The following is a description of a gene set: Human Gene Set: E2F1DP1RB_01 Genes having at least one occurrence of the motif TTTSGCGC in the regions spanning 4 kb centered on their transcription starting sites. This matches the E2F1, TFDP1, RB1 transcription factor binding site V$E2F1DP1RB_01 (v7.4 TRANSFAC). studied in species Homo sapiens, and this is the list of marker genes: CAND1, POLA2, RAB11B, MCMBP, E2F8, ATAD2, ATF5, POU4F1, SYNGR4, RTBDN, SRSF1, PRPS1, PAN2, MCM8, RFC1, PODN, POLR2A, TRMT13, UBR7, ZBTB4, HOXC10, CBX5, ZSWIM9, YTHDC1, ARHGAP11A, CORT, DCK, NIPBL, DNMT1, ILF3-DT, MCM6, PPM1D, CDT1, EZH2, GMNN, NFATC2IP, EMSY, GRIA4, ALDH6A1, PEG3, SLC9A5, SPTB, ZIM2, TMEM143, MTF2, MAPT, STMN1, CCNT1, RBPJ, TYRO3, ONECUT1, PPIG, TRMT6, RAD51, IMPDH2, ANKHD1-EIF4EBP3, RAVER1, ASXL2, JADE1, RMI2, JADE2, SRSF7, NRP2, SMC3, STAG2, SIK2, GABRB3 (NCBI Gene Id 2562), PRRC2C, INTS7 (integrator complex subunit 7), EPHB1, ATRX, POLR1G, DNAJC11, CTDSP1, IL4I1, ID3 (NCBI Gene Id 3399), ARHGAP6, HNRNPA1, KMT5A, POLE2, SRSF2, HNRNPUL1, DPYSL2, FHOD1, BRME1, ZNF565, PPP1R8, CDC25A, NECTIN1, RET, ARID4A, DMD, PCNA, KCNA6, MXD3, GSPT1, TMPO (NCBI Gene Id 7112), TLE3, MCM7, OTUD7B, MSH2, PNMA3, LHX5, ADAMTS2, LUC7L3, UGGT1, E2F1, WDR62 (WD repeat domain 62), MCM3, NASP, ZNF367, NUFIP2, GEN1, ING3 (NCBI Gene Id 54556), POLD1, ZNF362, ACBD6, STK35, IPO7, SOAT1, SLCO3A1, HNRNPD, PCSK1, OLFML3, KBTBD6, ILF3, CTCF, FIZ1, HCN3, ZNF524, SMAD6, EIF1AX, ZNF644, EED, LIG1, AP4M1, CASP8AP2, RPS6KA5, SLC6A4, SP3, UNG, KANSL3, RHCE, ZNF503, HS6ST3, SMC6, MYH10, ANKHD1, MCM2, GPAT2, ST20-AS1, PAPOLG, TOPBP1, NPR3, GINS3, KPNB1, CDCA7, WEE1, IER5L, DNAJC5G, APH1A, H2AC12, SASS6, RASAL2, E2F7, RHD, H2BC12 (NCBI Gene Id 85236), NUP62, SPTSSB, SLC25A14 (NCBI Gene Id 9016, solute carrier family 25 member 14), DNAJC9, MDGA1, NELL2, CLSPN, ZBTB25, MAT2A, PHC1, SEZ6 (seizure related 6 homolog), STT3B, KBTBD7, RRM2, PHF13, CLTA, HNRNPR, GAPDH, TAOK2, KLF4 (KLF transcription factor 4), PPP1CC, DCTPP1, PAX6, EHBP1, GON7, EIF4A1, SUMO1, NABP2, FBXO5, HMGN2, TBX6, RBBP7, ZNF687, ZMYM2, TFAP4, CTDSPL2, THAP8, PAQR4, NCL, AK2, POLD3, PCYT2, DDB2, TMEM187, TIGAR, NOLC1, CDC6, MAZ, YBX2, H2AZ1, USP37, PIM1, ZCCHC8, POLA1, PKMYT1, BRMS1L, MAPK6, SLC38A1, MEIS2, PCLAF, FMO4, CDK1, GPRC5B, POLE4, SNRPD1, ATAD5